Given this list of marker genes Nup133, Ppp2r5d, Ube2e1, Seh1l, Aurkb, Dync1li2, Nde1, Cenpq, Cdc26, Ube2c, Anapc7, Xpo1, Kif2c, Cenpt, Cenpa, Ppp2r5a, Cdc23, Anapc15, Itgb3bp, Kif2b, Ndel1, Kntc1, Ube2s, Nup85, Dynll1, Ska1, Nudc, Zwilch, Cenps, Plk1 (polo like kinase 1), Cenpu, Mis12, Clasp1, Cenpm (centromere protein M), Mad2l1, Ppp2r1b, Ube2d1, Anapc2, Mad1l1, Cenpn, B9d2, Spc24, Anapc10, Ndc80, Cenpe, Ppp2r5b, here is a description of the gene set: This event has been computationally inferred from an event that has been demonstrated in another species.<p>The inference is based on the homology mapping from PANTHER. Briefly, reactions for which all involved PhysicalEntities (in input, output and catalyst) have a mapped orthologue/paralogue (for complexes at least 75% of components must have a mapping) are inferred to the other species. part of: Cell Cycle Checkpoints electronically inferred by orthology from the curated human pathway studied in species Mus musculus Reactome Pathway: Mitotic Spindle Checkpoint